Given this list of marker genes MTMR3, CHRM5, MTMR1, MTMR9, MTMR2, here is a description of the gene set: Human Gene Set: GOBP_REGULATION_OF_PHOSPHATIDYLINOSITOL_DEPHOSPHORYLATION species: Homo sapiens Any process that modulates the frequency, rate or extent of the chemical reaction involving the removal of one or more phosphate groups from a phosphatidylinositol.